Given this list of marker genes ZNF439, CLIC5, RDH10, CTSL, CCRL2 (NCBI Gene Id 9034), ETV6 (ETS variant transcription factor 6), DESI1, GLS, FAM193B, KIF13B, DDIT4, VEGFA, FES, IER5, RUBCN, ANKS1A, CNPPD1, TBC1D9B, CLEC16A, RSAD2, TOB2, LACC1, LYST, PIGG, RETSAT, RXRA, GPR68, DENND1B, AACS, VRTN, SELENOS, SAMSN1, GRB10, SMIM17, SOCS1, LTC4S, EXOC3-AS1, LEPR, ASCC1, KCTD2, MDM2, MAPKAPK2, TSPOAP1, SOCS5, ZNF140, CHRNG, STAT3, NFKBIZ, NAMPT, SFT2D2, DEGS1, STX1A, ZNF549, TMEM200A, PSME4, ZNF557, PPP1R16B, UBC, MAST4, ADAM8, IL2RB, TNFRSF9, MIR663AHG, ANK3, ZNF561, ST3GAL2, PDE4D, DDIT3, CD3D, INPP5A, AP5Z1, HBEGF, SLC31A2, SMAD6, SLC66A1LP, PHLDA1 (pleckstrin homology like domain family A member 1), ALDH8A1, NR4A2, CAPG, TMED9, PLAUR, C6orf52, RASAL3 (NCBI Gene Id 64926), DRAM1, IFIT2, RNF19A, TIMP1, TMEM205, HCAR1, DDAH2, CD6, PTGER4, NFE2L1, JUN, CSNK1E, CALCB, SERPINC1, KLC1, ZNF222, SLC7A5, FADS3, ELMOD3, HGSNAT, CLCF1, PDGFA, SDF4, ZSCAN32, MBOAT7, EBI3, EGR1 (NCBI Gene Id 1958), HOMER1, DBH-AS1, PBOV1 (prostate and breast cancer overexpressed 1), ATF3, ARPP19, GHRH, ITPKC, CYB5R1 (cytochrome b5 reductase 1), AREG, CYP20A1, PDE3B, IRAK2, DERL1, BCL2A1, SLC7A11, ALK, DCUN1D3, CYTIP, C15orf48, ARIH2, FAM241B, RIN2, NOD2, TANK, DEF8, GNAS, SATB1, MAEA, RAP1A, SLC25A44, PLXNA1, CPQ, WNK1, CEBPB, PPM1F, PLEKHM2, SH2D2A, RNASEK, CAB39L, NRN1, BTBD18, PPIP5K1, DNAJB2, CIRBP, TLE3, TMEM225B, BRINP3, CNNM1, KCTD11, ZNF559, ZNF563, TNFRSF18, IRGQ, ZNF329 (NCBI Gene Id 79673), SLCO5A1, LOXHD1, CTSK, LAG3, MFHAS1, ARFGAP1, GALNT4, P4HA2, MOCOS, GNA12, TMIGD2, EDNRB-AS1, ANXA7, ZFYVE21, CYSLTR1 (cysteinyl leukotriene receptor 1), MAFF, FAM114A2, ITPR2, RABAC1, TUBB2A, CD38, NOP14-AS1, CMPK2, PELI1, BTG2, CMTM1, LRIF1, CSRNP1, METRNL, MBD6, SCARNA17, OASL, DUSP4 (NCBI Gene Id 1846), here is a description of the gene set: Human Gene Set: GSE2770_TGFB_AND_IL4_VS_IL12_TREATED_ACT_CD4_TCELL_2H_DN studied in species Homo sapiens Genes down-regulated in CD4 T cells activated by anti-CD3 and anti-CD28: TGFB1 and IL4 (2h) versus IL-12 (2h). Th1 and Th2 cells arise from a common precursor cell in response to triggering through the TCR and cytokine receptors for IL-12 or IL-4. This leads to activation of complex signaling pathways, which are not known in detail. Disturbances in the balance between type 1 and type 2 responses can lead to certain immune-mediated diseases. Thus, it is important to understand how Th1 and Th2 cells are generated. To clarify the mechanisms as to how IL-12 and IL-4 induce Th1 and Th2 differentiation and how TGF-beta can inhibit this process, we have used oligonucleotide arrays to examine the early polarization of Th1 and Th2 cells in the presence and absence of TGF-beta after 0, 2, 6 and 48 hours of polarization. from publication Lund R, Aittokallio T, Nevalainen O, Lahesmaa R (PMID 14607935)